Given this list of marker genes SKI, VIPAS39, MRPS26, TMBIM1, CDC42EP3, IER2, ARL4C, ACVR2B, VAMP1, PIAS3, FAM110B, UHRF2, RPL3, RPL23A, MBLAC2, TENT5C, FURIN, GAB3, FNIP2, EIF3H, TREML1, RNF144B, PPM1H, CLASP2, SGK1, PHLPP1 (NCBI Gene Id 23239), ALDH9A1, MTMR3, STX17, MAFB, MPEG1, VPS54, KIF18A, DDX46, GNA12, LRRC27, DNMBP, PIP4K2A, NUDT6, LTC4S, INSYN2A, CYTH1, ARID2 (AT-rich interaction domain 2), PDCD4 (NCBI Gene Id 27250), VMAC, C2orf76, RPL18, ANKRD13D, ABCD2, BEX3, RPS19, CLK1, SOX4, TLE1, OBI1, CAMSAP2, FGFBP3, ZNF878, SLC26A11, SLC45A4, DDX3X, RMDN1, ZKSCAN4, ZNF229, TRIM32 (tripartite motif containing 32), ZNF12, KIF5C, WDR11 (NCBI Gene Id 79207), AFF4, ZNF394, C1orf159, CBX7, PLXNA2, BORCS5, OSBPL11 (NCBI Gene Id 95889), XPC, WWC2, KXD1, DHRS3, MBP, SEC62, TBC1D14, CDT1 (NCBI Gene Id 81620), DIP2B, RPL18A (NCBI Gene Id 6142), RNF180, TMEM86A, ZFHX3, ZFYVE28, KIAA0586, SENP2, IP6K1, RAMP1, MATK, SLC25A13, USP2, MXD4 (MAX dimerization protein 4), CYP4F3, JMJD1C, ZNF579, GASK1B (golgi associated kinase 1B), NXPE4, ECT2, CD34, GPR183, SULF2, EYA4, ZNF608 (NCBI Gene Id 57507), MON2, TMEM109, HSD17B11, F8, CBX3, MND1, FUT10, TCEAL1, ARFGEF3, MARCHF6, PARP2, SLC38A9, FAM168B (NCBI Gene Id 130074), ID2, SLC43A2, RASSF2, KIF11 (NCBI Gene Id 3832), ANKRD39, MIS18A, IFFO1, SMAD7, ANKH, RPL31 (ribosomal protein L31), ZSCAN26, HERPUD2, HMGA2, TFDP1 (NCBI Gene Id 7027), LPIN1, NCOA2 (NCBI Gene Id 10499), ZBTB8A, ARHGAP19, COPRS, MAPKAPK3, CENPA, EID1, LIFR, YPEL3, CYTIP, FIG4, HDAC5, TGFBR1, RXRA, SLC2A4RG, UTP14A, KITLG, POLG2, CD207, DCLRE1C, NME3, NR1D1 (NCBI Gene Id 9572), KLF11, MCM4, GINS1, ZKSCAN1, RPS11, KIAA1217, KCNQ1OT1, NCKIPSD, TFDP2, SLC37A2, MED7, ZNF250, MCM7, TAL1, MTUS1, ZNF124, ZBTB25 (zinc finger and BTB domain containing 25), PDE3B, GPR155, WDR19, MEF2A, MSH2, GDPD5, GAS2L3, AATK (apoptosis associated tyrosine kinase), TBC1D32, NEURL2, GPCPD1, MED17, DGKZ, CARD6, AKT1, IRF8, TNPO1, RPS3A, RPL6, RNF215, PNPLA7, BMF, PAIP2, GNPDA1, DPY19L4, here is a description of the gene set: species: Homo sapiens from publication Ochiai K, Maienschein-Cline M, Simonetti G, Chen J, Rosenthal R, Brink R, Chong AS, Klein U, Dinner AR, Singh H, Sciammas R (PMID 23684984) Genes up-regulated in at day 0 B cell IRF4-KO versus at day 0 B cell wildtype. Temporal analysis of B cell activation in vitro using CD40L and IL-2/4/5 cytokines in wild type Irf4+/+ B cells or in mutant Irf4-/- B cells harboring a tet-inducible allele of Irf4. IRF4 expression was restored, or not, in the Irf4-/- background by culturing in the presence of low or high concentrations of doxycycline. The results provide insight in the role of IRF4 expression levels in coordinating different programs of B cell differentiation. Human Gene Set: GSE46606_IRF4_KO_VS_WT_UNSTIM_BCELL_UP